Given this list of marker genes SRD5A3, HCN4, CSRNP3, PCDHA9, PCDHA13, DLX3, CACNA1E, ADH6, PCDHA10, HYAL2, PER1, YWHAE, PCDHAC1, USB1, YIPF3, TRIM38, GNAO1, PELI1, NAGA, ALPK3, TNFRSF10B, CLCN5, LTBP2, ARFGEF3, GSK3B, SLC6A6, ANKH, CALU, SLC22A23, TP53INP2, PCDHA6, ANK1, MAP6, CCNK, CD8B, MYCL, C2CD6, GCK, PABIR3, RABGAP1L, TSPYL2, IGSF3, LDB1, HTR1D, LLCFC1, MUC22 (mucin 22, NCBI Gene Id 730409), HSPB6, PM20D1, ANKRD45, EFNA1, KDM2A, PAK1, PDE4D, SYT6, HEY2, PLEKHG6, NPTX1, CEP120, PCDHA2, CDC42BPA, ARRB1, SDC3, USP49, SCN4B, PRELP, PABPC1L2B, RNF220, METTL8, CAMK1D, CREB3L2, TRIM58, PRELID2, WNT1, HNF1B, ZC4H2, CNGA2, BCAM, SCN2B, PARVA, PABPC1L2A, PCDHA7, WNT9B, MAP3K3, SERPINB8, HLA-E, TBL1XR1, EXD2, SLC17A7, KIF21B, STX6, EIF1AD, SIX2, CCDC97, TOM1L2, FST, CD164, PIP4K2C, STK40, GANAB, MTSS2, TBL1X, EXTL3, TCHHL1, RIMS4, APOBEC2, SLC36A1, ATAT1, FNDC9, MYEOV, ZNF569 (zinc finger protein 569), NRM, AMT, MPDU1-AS1, MLLT11, DISC1, ZNF385A, PCDHAC2, HIP1, HNRNPL, TRIM66, SHISAL1, SSR2, HDAC3, PCDHA8, PPP4R1, PCDHA11, PSEN1, MARCKSL1, SMARCC2, CRNKL1 (crooked neck pre-mRNA splicing factor 1), FMNL3, PLP1, SPIRE1, DNAJB1, AMER1, SNX20, ZCCHC4, MORC4, NAPA, XYLB, FAM163B, GIGYF2, AHCYL1, SHISA6, ETV3L, CD209, TFDP1, ERAL1 (NCBI Gene Id 26284), PCDHA5, DYNLL2, CORO1C, INTS5, LHX2, PPP1R13L, EIF1, DNAJC5G, ARF4, UBE3A, RNASE13, PLBD2, RAPGEF1, BEND4, MRTFA, USP36 (ubiquitin specific peptidase 36), SIGLEC1, CRIPT, IKZF1, RBPJL, NDFIP1, CLASP2, CHCHD3, RBM20, CHRNA2 (NCBI Gene Id 1135), EYA3, ARHGAP24, CDR2, SHANK1, FZD4, PCDHA4, MLF2, IER5, SCAMP5 (secretory carrier membrane protein 5), SNX19, PLSCR3, OPCML, CCDC102A, PCDHA12, CASP2, NR2E3, SYP, ZNF407, ZNF703, METTL25B, HOXC6, ASIC1, RIBC1, MGLL, CXCL17, NAIP, GET3, NEUROD2, RAPGEFL1, VTI1A, LINC02801, ADARB2 (NCBI Gene Id 55523), FAM168A, CADM3, PRKCG, C19orf47, SSBP2, RPH3A, MTCL2, SH3TC2, RPS6KA2, SMAD2, RAB5B, MRPL19, KCNB1, EHMT2, HERC1, LRRC27, VGLL3, KCNA6, SEC24D, FOXRED2, SEMA4G, PCDHA3, FIGNL2, SREBF2, PEX11A, HIPK2, MTHFR, PCDHA1, ZNF444, here is a description of the gene set: from publication Chen Y, Wang X (PMID 31504780) Human Gene Set: MIR6731_5P species: Homo sapiens Genes predicted to be targets of miRBase v22 microRNA hsa-miR-6731-5p in miRDB v6.0 with MirTarget v4 prediction scores > 80 (high confidence targets).